Given this list of marker genes SYDE1, TIAM1, CORO1C, TSC1, RALGAPA1, MTSS2, ECT2, RANGAP1, EPHA2, SIPA1L1, RALGAPB, RHOG, CCDC125, ARHGAP42, RASGRP1, TBC1D7, PIP5K1A, ARHGEF16, ABR, BCR, APC2, SCRIB, SYDE2, RALGAPA2, here is a description of the gene set: studied in species Homo sapiens Human Gene Set: GOBP_ACTIVATION_OF_GTPASE_ACTIVITY Any process that initiates the activity of an inactive GTPase through the replacement of GDP by GTP.